The following is a description of a gene set: Spinal dysraphism species: Homo sapiens A heterogeneous group of congenital spinal anomalies that result from defective closure of the neural tube early in fetal life. Human Gene Set: HP_SPINAL_DYSRAPHISM, and this is the list of marker genes: ARVCF, IKBKG, BAZ1B, FLNA, SEC24C, CREBBP, PSAT1, FANCE, RORA, B3GLCT (NCBI Gene Id 145173), KIF22, RBM8A, ELN, PTDSS1, CHRNG, BRCA1, MTRR, FLNB, FUZ, PORCN, ITGB4, ERCC4, PIK3CA, CHN1, COLEC10, PALB2, CCNQ, RIPPLY2, RMRP, SALL4, RAB23, RAD51, UFD1, LIG4, DLK1, LIMK1, GDF6, BRIP1, CDK13, STX1A, SUPT16H, FANCD2, CLIP2, PTPN11, RTL1, TBX1, FANCB, DNAJC30, NEK9, GP1BB, EP300, CCL2, RFC2, ATP6V1B2, FANCI, POLA1, ARID1B, TNXB, FIBP, MYH3, HAAO, UBA2, MTHFD1, FANCG, AMER1, SLX4, ZIC1, CUL7, RAD51C, PAX3, COMT, BICD2, TBL2, MTR, SNRPB, SLC26A2 (solute carrier family 26 member 2), SOX9, DLL4, RREB1, FANCA, EBF3, SRRM2, SLC25A19, MASP1, NF1, DACT1, NCF1, VPS37D, MEG3, BRCA2, IRF6, LMX1B, HRAS, BUD23, FANCM, MAP3K7, GDF3, BRAF, MESP2, KANSL1, PTCH1, TBC1D24, GTF2IRD2, MAFB, EFEMP2, LFNG, FLI1, ACTB, MEOX1, PHGDH, GTF2IRD1, PLEC, UBE2T, RECQL4, FKBP6, TBXT, HMX1, GTF2I, DARS1, JMJD1C (jumonji domain containing 1C), RFWD3, TMEM270, FANCF, WBP11, RPS19, EIF4H, RAF1, TBX6, NSUN2, HES7, MAD2L2, VANGL2, CCBE1, XRCC2, FANCC, MTHFR (NCBI Gene Id 4524), METTL27, COL18A1, NOTCH2NLC, PUF60, BMS1, RUNX2, TRIM36, DLL3, VANGL1, KCNH1, BMP2, COLEC11, HIRA, FANCL